The following is a description of a gene set: part of: Drug resistance in ERBB2 KD mutants Reactome Pathway: Resistance of ERBB2 KD mutants to neratinib This pathway describes resistance of ERBB2 KD mutants to tyrosine kinase inhibitor neratinib. species: Homo sapiens, and this is the list of marker genes: ERBB2, HSP90AA1, ERBIN, CDC37